The following is a description of a gene set: Mouse Gene Set: REACTOME_RHOBTB2_GTPASE_CYCLE studied in species Mus musculus RHOBTB2 GTPase cycle, and this is the list of marker genes: Cct2, Txnl1, Hnrnpc, Cct6a, Cul3, Myo6, Cdc37, Rhobtb2, Actg1, Stk38, Ddx39b, Tmod3, Tra2b, Twf1, Rbmx, Phip (NCBI Gene Id 83946), Srrm1, Hsp90aa1, Actn1, Hsp90ab1, Cct7, Msi2